Given this list of marker genes Trappc4, Cog3, Asap2, B4galt7, Cant1, Lyz2, Smpd3 (NCBI Gene Id 80691), Tmed2, Fut8, Bet1, Slc10a7, Pld1, B4galnt4, Chsy3 (chondroitin sulfate synthase 3), B3galt6, Golph3, Nagpa, Vrk1, Fut4, B4galt5, Nucb1, H2-Q1, Chsy1, Atp2c1, Lyz1, Furin, Golga7 (NCBI Gene Id 97499), Mgat4a, Abo, Tmem115, Sorl1, Sar1a, Mgat2, Mgat4d, Atl1, H2-Q2, St3gal2, Sulf2, Cit, Csgalnact1, St3gal3, Fut7, Golt1a, Inpp5e, Nucb2, Dnmbp, Gal3st2, Cimap3, Golga2, H2-Q4, Xylt1, Sar1b, Scfd1, Gorasp2, Llgl1, Galnt1, B4galt3, Sec1, Acp3, Yipf2, Mbtps1, Pcsk5 (NCBI Gene Id 18552), Zfyve1, Golga3, St6gal2, Uxs1, Tmem87a, Golph3l, St3gal4, Sort1, Nsfl1c, Aph1a, H2-Q7, Nsf, Necab3, Mob4, Stx16, Tom1l1, Akap9, Ica1, Yipf1, A3galt2 (NCBI Gene Id 215493), H2-Q10, Lypla2, B4galt2, Cog2, Rasip1, Gcnt1, Rab21 (NCBI Gene Id 216344), Fut1, B4galt1, Nsg2, Tmbim4, Rab27b, Fut2, Golim4, Mgat4b, Slc30a5, Bet1l, Sulf1, Clip3, Rab14, Glg1, Galnt3, St6gal1, Marchf9, Chpf (chondroitin polymerizing factor), Lpcat2, Rab34, Fut11, Gpr89 (G protein-coupled receptor 89), Rab30, Gal3st3, Nsg1, Galnt2, Yipf6, Psenen, Hid1, Arap1, Golga5, Gbf1 (NCBI Gene Id 73518), Ggta1, 4930568D16Rik, B4galnt3, Tmem87b, H2-Q6, Plk3, Bcap31, Tmem59, H2-K1, Tmed3, B4galt6 (UDP-Gal:betaGlcNAc beta 1,4-galactosyltransferase, polypeptide 6), Lyset, Slc30a7, Cln3, Marchf4, Uso1, St3gal1, Csgalnact2, Vcpip1, Sgms1, Gosr1, Hace1, Iigp1, H2-D1, Man2a1, Hspd1, Pitpnm1, here is a description of the gene set: studied in species Mus musculus The set of thin, flattened membrane-bounded compartments, called cisternae, that form the central portion of the Golgi complex. The stack usually comprises cis, medial, and trans cisternae; the cis- and trans-Golgi networks are not considered part of the stack. Mouse Gene Set: GOCC_GOLGI_STACK